The following is a description of a gene set: species: Mus musculus The process whose specific outcome is the progression of a keratinocyte over time, from its formation to the mature structure. Mouse Gene Set: GOBP_KERATINOCYTE_DEVELOPMENT, and this is the list of marker genes: Psap, Sfn, Tfap2a, Fosl2, Cdsn, Bcl11b, Dnase1l2, Krt2, Flnb, Krt10, Ift74, Kdf1, Tfap2c, Abca12, Plec, Exph5, Palld